The following is a description of a gene set: Phosphodiesterases in neuronal function studied in species Homo sapiens Human Gene Set: WP_PHOSPHODIESTERASES_IN_NEURONAL_FUNCTION, and this is the list of marker genes: PDE7A, ADCY10, PDE8A, PDE5A, CREB1, PDE4D, GRIN2A, PDE4C, GUCY1A1 (guanylate cyclase 1 soluble subunit alpha 1), PDE8B, ADCY1, PDE6H, GUCY1B1, GRIN2B, ADCY6, ADCY8, PDE12, NOS1, ADCY4 (adenylate cyclase 4), DRD1, ADCY2, PPP1R1B, PDE1B, PDE9A, PDE11A, DRD2, PDE3B, PDE1A, PDE3A (NCBI Gene Id 8080), PDE2A, GRIN2C, GRIA1, GRIN2D, CHRNA7, ADORA2A, PDE6C, PDE6D, PDE6A, PDE6B, GUCY1B2, PDE10A, PDE1C, GRIN1, PDE4A, PDE6G, GUCY1A2, PDE7B (NCBI Gene Id 27115), ADCY3, ADCY7, PRKACA, ADCY9, ADCY5, CAMK2A (calcium/calmodulin dependent protein kinase II alpha), PRKG1, PDE4B (NCBI Gene Id 5142)